The following is a description of a gene set: Eicosanoid metabolism via cyclooxygenases (COX) Mouse Gene Set: WP_EICOSANOID_METABOLISM_VIA_CYCLOOXYGENASES_COX studied in species Mus musculus, and this is the list of marker genes: Ptgfr, Pla2g6, Pla2g4b, Ehhadh, Ptgdr, Acox3, Akr1b1, Cyp4a12a, Ptgr1 (NCBI Gene Id 67103), Pla2g5, Ptgds, Ptgs2, Cyp4a12b, Acaa1a, Pla2g4a, Ppard, Ptgir, Hpgd, Ptgr2, Cyp4f14, Tbxa2r, Ptgdr2, Tbxas1, Prxl2b, Ptgs1, Ptges (prostaglandin E synthase), Acox1, Cyp4a10, Acox2, Cyp4f18